Given this list of marker genes ITPR1, KRT86, SOD3, PCSK1, AQP4, SYNE1, MOAP1, DMBT1, RHOD, DDX17, GSTA4, CXCR4, PRKCB, CD200, GPM6A, RUNX1T1, BCKDHA, SLC39A6, UBL3, CRYAB, PPP4R2, RBP1, CHST15, VCAN, MAPK8IP2, PSD, EPHX1, CDH4, PTPRN, FGFR3, BTBD3, MTUS1, LY6H, SH3GL3, IQSEC1, PRKCZ, RIMS2, RAB11B, KRT31, ALCAM, OAZ2, GET1, HRAS, TUSC3 (NCBI Gene Id 7991), MAP7, NAP1L3, QDPR, CADM1, NEURL1, GAD1, GFAP, PDE8B, CELF2, ABCC8, PDE2A, AP3M2, CRYM, AGT, CLDN10, RGS5, NNAT, SYT1, IGFBP2, PTP4A3, MAPT, NTNG1, CLEC3B, CSRP2, MEF2C, NOVA2, APBA2, CBLN1, FOXO4, S100B, RGS7, WASF3, TIMP3, SORBS2, AMT, ATP9A, ITM2A, APOD, TRPM2, PENK, SERPINA3, ARHGEF4, SPP1, SGCE, TRPC4AP, ERBB3, GBF1, ZBTB18, IFIT1, ENO2, NAB2, GUCY1B1 (guanylate cyclase 1 soluble subunit beta 1), PAX4, RREB1, CDH22, PAX6, GABRB3 (NCBI Gene Id 2562), GAGE12F, HAGH, NOVA1, PDE4B, KLK6, SV2B, SERPINA1, PRKACB, TLE2, MAL, VGF, NR1D1, ENPP2, CARD10, RTN1 (NCBI Gene Id 8108), TRIM2, FEZ1, LIPA, RNF144A, ST18, SERPINI1, RPH3A, ANOS1, SPHK2, ALB, NCAM1, SFRP1, TMEM47, CACNB3, APBB1, LMO3, NHERF1, CELSR3, TCF7, PLCB1, CACNA1A, ITPKA, SLC17A7, TMSB15A, RASSF2 (Ras association domain family member 2), MAGI2, TSPYL2, MEGF9, GDPD5 (glycerophosphodiester phosphodiesterase domain containing 5), HSPA2, CORT, SGK1, FBXL7 (F-box and leucine rich repeat protein 7), TAGLN3 (NCBI Gene Id 29114), RALGPS1, SMARCD3, STOML1, AMPH, CARTPT, BMERB1, TRIM9, FZD7, PLCH2, TFAP2B, MBP, MYRF, MYO10, DVL1, ABCC5, STMN1, GPRC5B, EDA, MLC1, WDR7, ZBTB20, RNF41, KCNK1, FZR1 (fizzy and cell division cycle 20 related 1, NCBI Gene Id 8855), ELMO1, TYRO3, MEIS2, LPL, FXYD1, UBXN1, GABBR2, SRPX, CBX6, SLC1A3, RCAN2, MTSS1, RBMS3, CD37, F3, LMO2, SH3BGR, PDGFRA, CD24, CHRNB1, CDH16, PTPRO, PPP1R1A, FKBP1B, PTGDS, ATP2B2, CAPN3, CPE, LAPTM5, MTMR9, INSIG1 (insulin induced gene 1), MAP2, ALDH4A1, CACNG3 (calcium voltage-gated channel auxiliary subunit gamma 3), TSPAN7, PRPF19, SNRK, KIF5C, BCL6, NPY, DBP, CHGB, CLDN5, ATP6V1D, PALM (paralemmin), COL9A2, GNAO1, ADGRL1, CDK18, PRSS2, EPB41L3, PTK2B, TACC2, SLC2A3, OLFM1, STMN2, MAPK10, RUNDC3A, SLC22A18AS, CALB1, ALDH7A1, FAT1, PRB4, IGSF3, DNM1, RAC3, DLG4, ANGPT1, SNAP91, CLIP3, GNG4, CALB2, GNB5, PLPP2, ARC, RHBDL1, LZTS3, BSN, ABCA3, GRIN1 (glutamate ionotropic receptor NMDA type subunit 1), ZIC2, HTR4, EFS, EFNB3, NFYC, PLP1, TSPAN8, MMD, RAB31, BCAS1, CEACAM3, GPRASP1 (NCBI Gene Id 9737), CHST1, COX7A1, RIMS3 (NCBI Gene Id 9783), CKMT1B, CDH2, ST3GAL5, ARHGDIG, SCN1B, PTPRZ1, EGR3, MTHFR, LHX2, TRO, ELL2, BRD4, CUL9, GALR3 (galanin receptor 3), TBR1, SCAMP5, DCX, MAOB, DKK4, TNC, THRA, GRIA2, BIN1, APLP1, DBN1, FOS, NRXN1, CCND2, PSPH, AKR1C1, NCAN, CTSF, RGS4, TRIM23 (NCBI Gene Id 373), DUSP8, FGB, RNF167, RGS1, SCHIP1, LGR5, SOX10, SYT5, KMT2A, RASL10A, GJA1, DPP6, BICD1, CHGA, RYR3, TM7SF2, NRGN, WIF1, NEFM, H4C3, KYAT1, DPYSL3, PKIA, TSPOAP1, CFAP410, NPTX1, BCL11A (NCBI Gene Id 55085), REV3L, COL9A3, FADS2, PLAAT3, IFI27, NEO1 (neogenin 1), PTPRN2, STAT2, VSNL1, ATP6V1G2, MAT1A, TCEAL4, FAM131A, CA11, CCK, FEV, SNCB, PSG7, SSTR2, GPA33, HPR, PARD6A, LARGE1, CNP, ORM2, PCDH9, ATOSB, SST, TLE1, ITGA7, DNAJB2, GLRB (NCBI Gene Id 2743), GRIK5, GPX3, NDN, GFPT2, EXD2, TRIM16, ABLIM3, H2BC21, GAP43, ACTL6B, STK39, B4GAT1, NCALD, FGF9, CNTNAP2, CRMP1, EPHA4, APOE, PCBP4, FAM107A, KLHDC3, RND1, SNAP25, ETV5, ATP2B1, SV2A, PTN, NECAP1, NEFL, CA2, HOPX, MYH11, DCLK1 (doublecortin like kinase 1, NCBI Gene Id 9201), ABLIM1 (actin binding LIM protein 1), SOX4, SCG2, ATP6V0A1, TMCC2, UBE2D1, ELAC2, DPYSL4, SOX9, SYNGR1, MXD4, PLXNA2, AQP1, HLF, MLLT11, PPP6R2, EDNRB, SCO2, ELAVL4, KRT4, INPP1, PEG10, AANAT, PKD1, STX1A, GSTM1, SLC23A2, RHOB, KCTD17 (potassium channel tetramerization domain containing 17), TSPYL4 (TSPY like 4), GABRG2, MAPK8IP3, GJB1, NEBL, NTRK2, MT1G, GCLC, RNASE1, TBC1D9 (TBC1 domain family member 9), SCN2B, CDH11, CBR1 (carbonyl reductase 1), PRPF6, SLC1A6, PSPHP1, FGFR2, MAOA, PER1, LDOC1, EPAS1, KIF1B, EFNA2, APC2, EVI2A, ADH1A, LDB2 (LIM domain binding 2), PLXNB1 (plexin B1), FAT2, L1CAM, GAD2, PHYHIP, ACSL1, SPTBN2, ALDH1A1, ADARB1, SLIT2, TIMM17B, BAIAP3, RSBN1 (NCBI Gene Id 54665), ITGA6, PTPRD, SLIT1, KIF21B, CA12 (carbonic anhydrase 12), PITPNB, KAT6B, MACIR, ELAVL2, HAP1, POMZP3, ANK3, MAPRE2, BCL9, CABP1, NUPR1, CRABP1, TUBGCP4, SCG5, GATM, ACSL6, ZBTB16, NRG2, EPN2, EEF1A2, TENM4, CORO1A, GABBR1, LMO4, TNF, CYB561, PCP4, FOXG1, NECAB3, TMX4, SETBP1, GALC, SNCG, KHDRBS3, POLR2J, CHL1, ST6GAL1, HSPA13, CACNA2D2, SELENOP, ATP1B2, FABP7, SPOCK1, CHN2, KCNJ4, DYNC1I1, THBS2, APOC1, FGFR1, ST6GALNAC4, GNG7, AHDC1, ABCA1, CCND1, DMTN, C1QB, ABAT, OMG, SNPH, COLGALT2, PLEKHB1, AAK1, SULT4A1, DTNB, MYLK, KIF3A, CSPG5, CA4, CEP135, CX3CR1, ARNT2, here is a description of the gene set: species: Homo sapiens Human Gene Set: MODULE_11 Genes in the cancer module 11.